Given this list of marker genes MT1H, MT1E, ZNF658, MT4, MT1DP, MT3, TSPO, MTF1, ATP13A2, MT1G, GABRB3, KCNK3, HVCN1, CREB1, MT1X, MT1HL1, MT2A (metallothionein 2A), MT1A, PARP1, MT1B, MT1M, GLRA2, GLRA1, MT1F, P2RX4, here is a description of the gene set: studied in species Homo sapiens Human Gene Set: GOBP_CELLULAR_RESPONSE_TO_ZINC_ION Any process that results in a change in state or activity of a cell (in terms of movement, secretion, enzyme production, gene expression, etc.) as a result of a zinc ion stimulus.